Given this list of marker genes Tap2, Rab5b, Il1rl1, Dbf4, Myf6, Hic1, Fancg, Ift27, here is a description of the gene set: from publication Bystrykh L, Weersing E, Dontje B, Sutton S, Pletcher MT, Wiltshire T, Su AI, Vellenga E, Wang J, Manly KF, Lu L, Chesler EJ, Alberts R, Jansen RC, Williams RW, Cooke MP, de Haan G (PMID 15711547) Genes whose expression is coregulated with that of FLI1 in hematopoietic stem cells (HSC). species: Mus musculus We combined large-scale mRNA expression analysis and gene mapping to identify genes and loci that control hematopoietic stem cell (HSC) function. We measured mRNA expression levels in purified HSCs isolated from a panel of densely genotyped recombinant inbred mouse strains. We mapped quantitative trait loci (QTLs) associated with variation in expression of thousands of transcripts. By comparing the physical transcript position with the location of the controlling QTL, we identified polymorphic cis-acting stem cell genes. We also identified multiple trans-acting control loci that modify expression of large numbers of genes. These groups of coregulated transcripts identify pathways that specify variation in stem cells. We illustrate this concept with the identification of candidate genes involved with HSC turnover. We compared expression QTLs in HSCs and brain from the same mice and identified both shared and tissue-specific QTLs. Our data are accessible through WebQTL, a web-based interface that allows custom genetic linkage analysis and identification of coregulated transcripts. Mouse Gene Set: BYSTRYKH_HEMATOPOIESIS_STEM_CELL_FLI1